The following is a description of a gene set: Genes predicted to be targets of miRBase v22 microRNA hsa-miR-6884-5p in miRDB v6.0 with MirTarget v4 prediction scores > 80 (high confidence targets). species: Homo sapiens Human Gene Set: MIR6884_5P from publication Chen Y, Wang X (PMID 31504780), and this is the list of marker genes: SLC35E2B, PAPPA, MGST3, ARSD, PCNX1, SOX5, KRT10-AS1, APLP2, ACTR3, ST3GAL1, PTMS, ARRB1, PLXNA4, DNAJC5G, ZNF609, TMEM132D, MDM4, OSBPL10, PLEKHA1, SYNGR1, GLIS3, PPARGC1A, AFG3L2, MMP15, SMG1, SHISA6, USP38 (ubiquitin specific peptidase 38), RGN, ZNF831, ETNK1, SLC26A9, QKI, MGAT5B, TDRP (testis development related protein), GPN3, KIAA1328, DFFA, ZSWIM6, MELTF, UBE2I, IBA57 (iron-sulfur cluster assembly factor IBA57), CYREN, FRMD5, TMEM120B, WDR35, VAT1, KCNB1, EFNA1, RAPGEFL1, PANK3, ABHD2, PEX12, CTDNEP1, ADIPOR2, SLC23A2, TAOK1, ZNF474, MSI2, MTMR11, DHCR24, FAM89B, NSD2, SSR1, DPP8, PHAF1, CKS1B, IKZF3, RBM4B, RNF182, RAB8B, ZBTB39, CDX1, PSD2, MRGPRF, HEYL, CLDN12, TMEM86A, HTR6, HOOK3, STX5, DPAGT1, DAG1, LRRC7, YWHAG, YTHDC1, MMP14, SGPL1, TMBIM6, CNKSR3, EFR3B, PSMA5, CCN2, SLC35F6, IGF2BP2, ONECUT2, FTO, HMGA2, SFRP5, POLE, APPBP2, LRP4, LDLRAD3, KIF6, MEOX1, SLC36A3, SSH2, PARP8, TTYH3, RICTOR, WBP2NL, EPB41L4A, DPYSL3, TMC8, CERS6, UPF2, ABR, GLCE, PHTF2, EEF2K, YIPF6, FKBP4, RBM4, BCAP29, SPTB, HIF3A, RPRD2, ASCC2, GABRB3, LRP8, UNC119B, CGNL1, FABP7, OGT, CEP85, ADAMTSL5, TMEM214, TFRC, GPI, CRIPT, GPR176, ATPAF2, MTCL2, FAM168A, NUCB1